Given this list of marker genes FOXC2, MIR451A, SMOC2 (NCBI Gene Id 64094), HTN1, XBP1, VEGFB, here is a description of the gene set: studied in species Homo sapiens Human Gene Set: GOBP_POSITIVE_REGULATION_OF_VASCULAR_WOUND_HEALING Any process that increases the rate, frequency, or extent of blood vessel formation when new vessels emerge from the proliferation of pre-existing blood vessels and contribute to the series of events that restore integrity to damaged vasculature.